Given this list of marker genes MTERF4, MRM1, MT-RNR2, MRM3, TRMT10C, NSUN4, MRM2, TFB1M, PRORP, HSD17B10, ELAC2, MT-RNR1, here is a description of the gene set: Human Gene Set: REACTOME_RRNA_PROCESSING_IN_THE_MITOCHONDRION species: Homo sapiens rRNA processing in the mitochondrion